Given this list of marker genes Ntrk1, Ap2s1, Cltc, Ap2a2, Sh3gl2, Ap2m1, Clta (clathrin light chain A), Ap2a1, Ngf, Dnal4, Ap2b1, here is a description of the gene set: species: Mus musculus Retrograde neurotrophin signalling Mouse Gene Set: REACTOME_RETROGRADE_NEUROTROPHIN_SIGNALLING